Given this list of marker genes ORC1, POLA2, ORC5, MCM8, PPP2CA, PPP2CB, TFDP2, POLA1, E2F1, TFDP1, CCNB1, PRIM2, PPP2R1A, CDK1, RB1, ORC6, ORC3, ORC2, PRIM1, ORC4, PPP2R3B, PPP2R1B, here is a description of the gene set: Progression through G1 and G1 to S-phase transition that initiates DNA synthesis involve many complexes that are regulated by RB1:E2F pathway. RB1:E2F pathway plays a key role in gene expression regulation in proliferating and differentiated cells. As a repressor, E2F remains bound to RB1; it can activate the expression of S-phase genes involved in DNA replication after the phosphorylation of RB1.<BR>E2F proteins regulate expression of genes involved in various processes thereby forming interlinks between cell cycle, DNA synthesis, DNA damage recognition etc.<BR>In this module, activation of replication related genes by E2F1 and two ways by which E2F1 regulates DNA replication initiation are annotated. part of: G1/S Transition Reactome Pathway: E2F mediated regulation of DNA replication studied in species Homo sapiens